Given this list of marker genes Syt14, Uba1y, Zfp830, Tcf20 (transcription factor 20), Fnip1, Crebl2, Sfpq, Nr3c1, Siah1a (NCBI Gene Id 20437), Ube2k, Abraxas2, Fgf14, Strn3, Amotl1, Tmem167, Adam17, Mavs, Fam228b, Epb41l3, Slc26a3, Dnaja4, Celf2, Msi2, Trap1a (tumor rejection antigen P1A), Zfp706, Myt1, Bhlhb9, Sf1, Klhdc10, Usp42, E2f2, Psip1, Msl2, Ak4, Slc39a14, Cxxc5, Dcaf17, Spx, Cth, Diaph2, Phf20l1, Gpd2, 6430550D23Rik, Aff3, Gpr149, Fgd5, Zfhx3, Chuk, Glb1l3, Rhag, Plaa, Nmt2, Unc79, Rasl12, Ciao2a, Ldlrad3, Tnrc6b, Nup98, Cd55, Rnpc3, Drap1, Ywhab, Fam171b, Plppr1, Vim, Fgr, Aph1a, Enam, Ccnb2, Jarid2 (NCBI Gene Id 97879), Dcaf10, Zfp597, Cttnbp2, Siah1b, Vps37a, Neil2, Hexim1, Maob, Spred1, here is a description of the gene set: Genes predicted to be targets of miRBase v22 microRNA mmu_miR_708_3p in miRDB v6.0 with MirTarget v4 prediction scores > 80 (high confidence targets). from publication Chen Y, Wang X (PMID 31504780) Mouse Gene Set: MIR_708_3P studied in species Mus musculus